The following is a description of a gene set: Human Gene Set: GSE19941_UNSTIM_VS_LPS_STIM_IL10_KO_MACROPHAGE_DN Genes down-regulated in IL10 knockout macrophages: unstimulated versus LPS. from publication Yang HT, Wang Y, Zhao X, Demissie E, Papoutsopoulou S, Mambole A, O'Garra A, Tomczak MF, Erdman SE, Fox JG, Ley SC, Horwitz BH (PMID 21217011) studied in species Homo sapiens Bone marrow-derived macrophages were produced from mice lacking IL-10 alone (IL10-def) or mice lacking both IL-10 and the p50/p105 subunit of NF-kB (p50/IL10), and left unstimulated, stimulated with LPS (1 ng/ml) or stimulated with LPS and IL-10 (0.3 ng/ml)., and this is the list of marker genes: TFCP2, SNRPA, ANTXR2, TBC1D30, CALHM6, WLS, PDE1A, VRK2, EMSY, FBLN1, EWSR1, TMCC1, SLC25A40, SNX3, EVI2A, SERPINC1, TNFAIP8L1 (NCBI Gene Id 126282), PEX19, TEAD1, PARP1, TRIM59, DUSP4, ZNF569, NCOA2, GEMIN2, TRIM44, DEF8, PSMB6, DCP2, ST8SIA6, PRKAG2, CDC25B, ATP2B1, ARRDC3, ZKSCAN8P1, GPC6, MST1R, TANC2, MORC3, SMARCC2, IFIT2, PHC1, LSP1, CFAP20DC, TROAP, FABP7, MMP12, TRMT44, BCL9, MRPL39, PAQR4, DOK2, RASA1, LRRCC1, F8, KCNMB2, HEXIM2, PDLIM2, USP47, ARID2, APLP2, FGF13, CELF2, INTS6L, CEP192, NEO1, IVD, CD1D, SESN1 (NCBI Gene Id 27244), OGDH, EMC2, AK2, ANXA1, CHAC2, EHHADH, CD84, CFAP20, HAUS8, AFF3, GABPA, IL17RB, C2orf69, EPDR1, PRKAR2B, PDHB, XIAP, SIX5, CST3, PSMA5, UBR7, PIP5K1B, CETN2, CPSF6, CKAP5, RASAL1 (NCBI Gene Id 8437), EXOSC3, PDE8A, KLF4, PIAS1, FGF21, OTUB2, EVL, CACNA1E, CEP89, LRRC40, CCDC34, S100A8, CDH1, N4BP2L2, CHTOP, TMC4, VSIG2, ANKDD1B, IFI44L, ENTPD5, DHX34, SHLD1, DIAPH2, AFMID, PRDM2, SVIL, BTK, PNPLA3, KLHL33, DUSP10, STT3B, SFMBT2, ZFAND4, APOBEC1, SLC25A53, DPYSL2, COG5, NCF2, NCOA7, ADGRE1, CCR8, CAVIN3, RPRD1A, SH3BGRL, CEP70, CNIH3, CPA6, PMEL, GCAT, S100PBP, NME7, FGD6, GTPBP1, PSMB7, ANKRD29, SLC25A51, B4GALT4, CSK, CHEK2, GPR34, SIX6, ITGB3, ZNF619, GPR174, ARHGAP19, URGCP, KRBA1, FAM20B, NSUN4, HS3ST1, CD83, SIK1, IFT172, SFMBT1, SLC4A7, NKAP, TANK, PENK, HNRNPUL2 (heterogeneous nuclear ribonucleoprotein U like 2), GBX1, IL10RB, ANKRD6, BEX1, SMC4, CCDC14, MDH1, ANKRD44, NUDT16L1, PSMB4, MEIOB, BTD, SIAE, TRAF5, KYNU, OSGEP, HJURP, SMARCA4, BCAS2, STK39, DUSP5, TMEM239, SLC25A45, SH2D3C, SIN3A, KATNB1